The following is a description of a gene set: Mouse Gene Set: GOBP_NEGATIVE_REGULATION_OF_PEPTIDYL_TYROSINE_PHOSPHORYLATION Any process that stops, prevents, or reduces the frequency, rate or extent of the phosphorylation of peptidyl-tyrosine. studied in species Mus musculus, and this is the list of marker genes: Hyal2, Chmp6, Prkcz, Nf2, Igf1, Lilrb4b, Ptpn2, Pibf1, Psen1, Hnf4a, Zgpat, Spink1, Dusp22, Socs4, Gprc5a, Irf1, Samsn1, Ptpn6, Cav1, Srcin1, Il18, Sh2d1b1, Socs1, Socs5, Pecam1, Ntf3, Ptk6, Socs3 (NCBI Gene Id 12702), Parp14 (NCBI Gene Id 72239), Suz12, Psen2, Ggnbp2, Sfrp1, Lrrk1, Vps25, Mvp, Inpp5f, Dmtn, Zfyve28, Sfrp2, Traf3ip1, Ptpn1, Ptprc, Cadm4, Cblc, Errfi1, Lilrb4a, Tsg101